The following is a description of a gene set: species: Mus musculus This event has been computationally inferred from an event that has been demonstrated in another species.<p>The inference is based on the homology mapping from PANTHER. Briefly, reactions for which all involved PhysicalEntities (in input, output and catalyst) have a mapped orthologue/paralogue (for complexes at least 75% of components must have a mapping) are inferred to the other species. part of: Zinc transporters Reactome Pathway: Zinc influx into cells by the SLC39 gene family electronically inferred by orthology from the curated human pathway, and this is the list of marker genes: Slc39a2, Slc39a14, Slc39a7, Slc39a6, Slc39a4